Given this list of marker genes LRPPRC, TEFM, MTG2, RPUSD3, KANSL3, RCC1L, RPUSD4, TRUB2, TACO1, KANSL1, TRMT10C, PRKAA1, CHCHD10, NGRN, KAT8, SHMT2 (serine hydroxymethyltransferase 2), MPV17L2, RMND1, METTL4, COA3 (NCBI Gene Id 28958), FASTKD2, FASTKD3, ALKBH1 (alkB homolog 1, histone H2A dioxygenase), MTG1, METTL8, DDX3X (NCBI Gene Id 730543), MIURF, MALSU1, UQCC2, CDK5RAP1, NSUN3, C1QBP, MTRES1, TSFM, THAP11, here is a description of the gene set: Any process that modulates the frequency, rate or extent of mitochondrial gene expression. Gene expression is the process in which a gene's coding sequence is converted into a mature gene product (protein or RNA). Human Gene Set: GOBP_REGULATION_OF_MITOCHONDRIAL_GENE_EXPRESSION species: Homo sapiens